The following is a description of a gene set: Human Gene Set: MIR5581_5P from publication Chen Y, Wang X (PMID 31504780) Genes predicted to be targets of miRBase v22 microRNA hsa-miR-5581-5p in miRDB v6.0 with MirTarget v4 prediction scores > 80 (high confidence targets). studied in species Homo sapiens, and this is the list of marker genes: PDX1, SHISA6, PTPRE, SUV39H2, HUNK, GRAMD1B, UBAP2L (ubiquitin associated protein 2 like), KANSL3, TCEAL7 (transcription elongation factor A like 7), UBXN10, PHOSPHO1, ZIC3, CSNK1D, MPP3, ZNF790, STEAP2, KDM5B, PAFAH1B1, UNC5D, SERPINA1, LHX6, RCOR1 (NCBI Gene Id 23186), CIBAR1, ANO3, PPP6R1, CPEB3, TFDP1, THSD7A, FGF1, ABL2, SHROOM4, UBXN7, THUMPD1, ZNF491, ATP6V1A, KCNRG, LATS1, FBLIM1, SLCO2A1, MARF1, RPP14, PI4KB, OSBPL8, ZNF608, IFFO2, PPFIA1 (NCBI Gene Id 8500), TGFBR1, ADCY1, SEMA5A, ABCD3, JMY, GPX5, BTG4, CHN2, MAU2, NWD1, CCDC62, CUX2 (NCBI Gene Id 23316), CAMK2G, MORC4, NEDD4L, ORMDL2, GABBR1, POU3F2, FBXL2, SHOC2, AQP4, FYCO1, EFNB1, AFG2A, GMEB1, MMP14, TBC1D9, FZD7, SH3PXD2A